The following is a description of a gene set: Neighborhood of AF1Q Neighborhood of AF1Q NULL in the GNF2 expression compendium studied in species Homo sapiens Human Gene Set: GNF2_AF1Q, and this is the list of marker genes: PTPRD, DCLK1, STMN4, DYNC1I1, GPM6A, ASTN1, NCAN, TUBB (NCBI Gene Id 95295), INA, ANK2, CLIP3, STMN2, MYT1L, ADCY1, RTN1, KIF3C, GAP43, CSPG5, KIF5C, GAD1, ATP9A, GNAO1, MLLT11, SOBP, RALYL